Given this list of marker genes MUC12, ST6GALNAC4, ST6GAL1, ST3GAL1, MUC2, MUC13, MUC20, MUC1, MUC7, MUC15, MUC19, MUCL1, MUC5AC, ST6GALNAC2, ST3GAL2, MUC17 (NCBI Gene Id 402576), MUC6, MUC4, MUC21, MUC16, MUC3A, ST6GALNAC3, ST3GAL3, MUC3B, MUC5B, ST3GAL4, here is a description of the gene set: part of: O-linked glycosylation of mucins species: Homo sapiens Reactome Pathway: Termination of O-glycan biosynthesis O-glycan biosynthesis can be terminated (or modified) by the addition of sialic acid residues on Core 1 and 2 glycoproteins by sialyltransferases.